Given this list of marker genes CTSL, LTF, HPX, GNLY, CALR, APOA1, HSP90AA1, APOE, HBA2, HBB, HSP90B1, HP, HSPH1, PGLYRP1, APOB, SCGB3A2, HBA1, SPARC, CSF3, HYOU1, SAA1, HGS, MPO, here is a description of the gene set: Human Gene Set: GOCC_ENDOCYTIC_VESICLE_LUMEN studied in species Homo sapiens The volume enclosed by the membrane of an endocytic vesicle.